The following is a description of a gene set: species: Mus musculus The process in which a relatively unspecialized cell acquires the specialized structural and/or functional features of a cell that will form part of the cardiac organ of an individual. Mouse Gene Set: GOBP_CARDIOCYTE_DIFFERENTIATION, and this is the list of marker genes: Zmpste24, Rgs2, Cited2, Tgfb2, Kdm6b, Tbx5, Ankrd11, 3425401B19Rik, Bvht, Jag1, Mir452, Dicer1, Nrp1, Arrb2, Hdac3, Sik1, Slc8a1, Pitx2, Pi16, Rbpj, Neb, Adprhl1, Srf, Itgb1, Hdac2, Ctcf, Fdps, Pin1rt1, Cacybp, Tbx2, Ift88, Alpk3, Yy1, Hnrnpu, Prickle1, Nkx2-6, Mylk3, Gata6, Irx3, Adra1b, Sema3c, Myh6, Wt1, Sirt1, Map2k4, G6pdx, Meis1, Myo18b, Arid1a, Sirt6, Sorbs2, Calr, Eomes, Pdgfb, Trip10, Gsk3b, Mir143, Cav3, Igf1, Tgfb1, Ctnnb1, Pdgfra (platelet derived growth factor receptor, alpha polypeptide), Pin1, Cby1, Mir208a, Acvr1, Prkg1, T, Gata4, Cripto, Atg7 (autophagy related 7), Vangl2, Popdc2, Dkk1, Acvr1b, Lrp6, Bves, Pdlim5, Sgcb, Shox2, Fzd7, Mtor, Prox1, Rxrb, Parp2, Frs2, Rgs4, Atg5, Ctdp1, Notch1, Dhx36, Kcnj8, Twist1, Cavin4, Alpk2, Akap13, Prok2, Efnb2, Hamp2, Ppara, Sgcd, Dll1, Myh11, Vcam1, Ccn4, Nebl, Tbx3, Grem1, Speg, Zfp418, Nr3c1, Asb2, Pax3, Folr1, Ang2, Cdc42, Eng (endoglin), Mef2c, Ccnd2, Lrrc10, Edn1, Mef2a, Col14a1, G6pd2, Tbx18, Ddx39b, Rara, Lmna, Rest, Ednra, Ift20, Nrap (NCBI Gene Id 18175), Mir145a, Smad6, Hand2, Myod1, Pdgfrb, Pak1, Sox17, Mapk3, Cxadr, Spry1, Myl2, Inhba, Xirp1, Mapk1, Large1, Sox18, Gsk3a, Fhod3, Rxra, Ttn, Maml1, Greb1l, Camk2d (calcium/calmodulin-dependent protein kinase II, delta), Smad4, Nkx2-5, Mylk2, Sox6, Foxp1, Bmp10 (NCBI Gene Id 12154), Gper1, Tcap, Vegfa, Tenm4, Slc9a1, Hes1, Plec, Isl1, Acadm, Bmp4, Tgfbr3, Myh10 (myosin, heavy polypeptide 10, non-muscle), Bmp2, Hey2, Ep300, Adra1a, Tomm70a, Myocd, Rarb, Agtr2, Cdk1, Bmp7, Kat2a, Actc1, Pdcd4, Fhl2, Tsc1, Nox4, Pbrm1, Hamp, Mesp1, Naglu, Akap6, Met (met proto-oncogene), Egfr, Bmpr1a, Csrp3, Actn2, Dyrk1a, Adrb1, Nrg1 (NCBI Gene Id 320603), Agt, AW551984, Slc25a4, Rbm10, Eef1ece2, Wnt3a